Given this list of marker genes HOXB5, UBE2L6, ERP29, ORC1, ACVRL1, DDX3Y, NDUFAF4 (NCBI Gene Id 29078), ABT1, NDUFS6, AFP, CTPS1, DNTT, SOAT1, LSM7, GGA2, H2AB2, MET, FAM241A, SLC3A2, IL6R, GML, EXOSC7, NPC2, RGS4, ENTPD5 (NCBI Gene Id 957), DAB1, SLC5A11, KCNK2, TASOR (transcription activation suppressor), ST6GALNAC2, GATA5, FAM3A, SCGB1A1, CTSE, APEX1, SMO, C1orf52, SPRYD4, F2RL3 (F2R like thrombin or trypsin receptor 3), CRNKL1, SHE, ADGRG3, ARID3B, HS3ST3A1, ARL4A, PRR15, WNT5B, TPD52L1, NHP2, BMP1, PSPH, FKBP4, UGGT1, FRMD8, SFXN1, TUBA4A, MFAP5, SLC6A3, HSPA1L, GRK6, UTP20 (UTP20 small subunit processome component), ASGR1, SLC26A1, DMGDH, ACRBP, TMUB2, ANXA10, BZW2, TIMP2, TBC1D24, IMMT, TGFBR1, SLC2A4, OAZ3, CILP2, PRUNE1, SEMA4B, PPIC, TMEM150A, GSN, AOAH, NR0B1, SPATS2, S1PR4, CRYBG1, CA6, RUNX1T1, DOLPP1, KCNJ5, IVD, NPHP1, FASTK, COPS2, MRPL38, ST3GAL1, SLC30A4, POU1F1, PAPOLB, BBS9, DPH5, SLC35A4, NEFH, CNN3, GLRX3, FOXRED1, MRPS18B, USP3, CACNA2D3, TMED8, THPO, FGF2, NPPA, HSD17B3, PRKCZ, TERT, SNTB1, ISLR, PDYN, FNTB, BEX4, MLYCD, RXYLT1, EOMES, HSD11B1, ARL4C, EFNA2, CTNND2, TUBA1A, PITPNB (phosphatidylinositol transfer protein beta), TUBB3, E2F3, CCR7, RMND1, GABPB1, PLXNB2, DAP, HDAC7, DRAP1, LHX8, PC, GABRD, MTMR10, GRAP2, RAP2B, RAMP2, NKX6-2, GAMT (NCBI Gene Id 2593), SIM2, BRK1 (NCBI Gene Id 55845), C6orf136, JPT1, PLA2G2C, GGT1, C15orf39, DPCD, AGRP, GRWD1, NDUFA10, ZNF653, WDR55, ZAN, MFAP4, IRAG1, SCMH1, AHCY, POLR2L, MYL12B, NFIA, EFNA1, GRIN1, AATK, CDH16, IL10RA, TRIM13, CHST3, GART, RFLNB, SORD, KCNJ11 (potassium inwardly rectifying channel subfamily J member 11), SELL, SMAGP, RCAN3, PKDCC, GLO1, CRADD, KRT17, PFDN5, SSRP1, GPX2, WWTR1, BANF1, CA4 (NCBI Gene Id 762), CRYM, LCOR, INA, VPS16, CD2, FGF1, PKIB, HSF1, here is a description of the gene set: Genes down-regulated in monocytes pre-treated with Ly294002: control versus HCMV infection. studied in species Homo sapiens Human cytomegalovirus (HCMV) induces pro-inflammatory monocytes following infection and we have evidence that phosphatidylinositol 3-kinase is a key mediator in this activation. To begin to address how this signalling pathway is responsible for the functional changes in infected monocytes, we examined the role this pathway played in the transcriptome of infected monocytes. Global transcriptional profiling using cDNA microarrays revealed a significant number of genes were regulated in a PI(3)K-dependent manner, identifying this pathway as a key cellular control point in the conversion of monocytes to an activated pro-inflammatory state following HCMV infection. Human Gene Set: GSE19772_CTRL_VS_HCMV_INF_MONOCYTES_AND_PI3K_INHIBITION_DN from publication Chan G, Nogalski MT, Bentz GL, Smith MS, Parmater A, Yurochko AD (PMID 20173022)